The following is a description of a gene set: Mouse Gene Set: GOBP_REGULATION_OF_POSITIVE_CHEMOTAXIS Any process that modulates the frequency, rate or extent of the directed movement of a motile cell or organism towards a higher concentration in a concentration gradient of a specific chemical. studied in species Mus musculus, and this is the list of marker genes: Il16, Creb3, Cxcl12, Scg2, F7, Vegfb, Vegfc, Casr, Akt2, Ntf3 (NCBI Gene Id 30909), Hmgb1, S1pr1 (sphingosine-1-phosphate receptor 1), Ptgr1, Ager, Itga2, F2rl1, Prkca, Ntrk3, Fgf10, Cdh13, Pgf, Vegfd, Vegfa, Angpt2, Ccl21a, Kdr (kinase insert domain protein receptor), Artn, Ccr4, Smad3